Given this list of marker genes CDH5, ACTG1, ABCB1, F11R, FLNA, TJP1, here is a description of the gene set: Human Gene Set: GOBP_PROTEIN_LOCALIZATION_TO_BICELLULAR_TIGHT_JUNCTION studied in species Homo sapiens A process in which a protein is transported to, or maintained in, a location within a bicellular tight junction.